The following is a description of a gene set: from publication Chen Y, Wang X (PMID 31504780) Human Gene Set: MIR15B_5P studied in species Homo sapiens Genes predicted to be targets of miRBase v22 microRNA hsa-miR-15b-5p in miRDB v6.0 with MirTarget v4 prediction scores > 80 (high confidence targets)., and this is the list of marker genes: RNF144B, LATS1, AHCYL2, CPEB2, APLN, NAA25 (NCBI Gene Id 80018), RBBP6, SIK1, SAMD10, SUMO3, ANKS1A, DENND4A, SEC24A, SYNRG, SUCO, KCNG4, RGMA, UBN2, BCL11B, DYNC1LI2, JARID2, RICTOR, ZNF449, SALL1, PRKAR2A, FAM135A, KRTAP11-1, TLK1, SGK1, PDIA6 (protein disulfide isomerase family A member 6), SIPA1L2, LAMP3, SLC2A3, DNAJA2, SEMA3D, CMC4, TMEM74B, SYDE2, MYO5B, RASSF8, SLC6A11, LURAP1L, C2orf42, QKI, PAFAH1B1, PCDH9, MIB1, CCDC83, MTFR1L, TARBP2, HECTD1, MCU, LUZP1, PAG1, CLUH, MAP2K1, JPH3, VTI1B, RFK, LDLRAD2, G2E3, SOX6, EZH1 (NCBI Gene Id 2145), SH3GL2, PLRG1, TMEM154, CHAC1 (NCBI Gene Id 79094), MAMSTR, CHUK, IARS1, HIGD1A (HIG1 hypoxia inducible domain family member 1A), ADRB2, RUNDC3B, ARMH4, ILDR2, TMEM199 (NCBI Gene Id 170473), SPTBN2, CCNJL, ZNF622, ATG9A, CXCR5, USP44, RASEF, RET, SPAG7, UROS, UBFD1, IKBKB, MEX3C, EXT2, ZCCHC2, MEOX2, NRP2, SEMA3A, ELL2, KCNJ2, PNPLA6, ZFHX4, IPPK, NSMF, ADAMTS3, SLIT2, FLT3, KRTAP4-6, COBLL1 (NCBI Gene Id 22837), PLXNC1, SEMA5B, PTPN4, GCC2, SLC4A4, ST8SIA3, RAD50, NUFIP2, TLL1, FBXL20, SYNJ1 (NCBI Gene Id 8867), ANLN, TFCP2L1, RBM6, GPN1, PTCH1, CMPK1, EPHB2, NOS1, G0S2, ATF6, CACUL1, MOB3B, PISD, CFAP45, AKT3, IPO7, KIF5C, PAPPA, BZW1, RARB, ANKUB1, PPP2R1B, TMEM135, PTPRR, NR2C2, SPRYD3, BMPR1A, SCN8A, FAM133B, SREK1, IVNS1ABP, ARPP19, TRANK1, CCNT1, SEPTIN2, HELZ, PPP1R11, DMPK, TMEM183A, TGFBR3, MOB4, NAPG (NSF attachment protein gamma), CASK, SOCS6, STOX2, ACSL4, CBX2, AGO1, ZNHIT6, PPT2, ARHGAP32, DIXDC1, NUP50, GALNT7, CDHR1, KIF1B, HERC6, CD2AP, HTR2A, ATXN1L, UBE4B, DPY19L4, SLC36A1, SNTB2, SAV1, AK4, CUX1, ASH1L, ZNRF2, USP3, SPRED1 (sprouty related EVH1 domain containing 1), FERMT2, PCMT1, PPM1A, NCS1 (neuronal calcium sensor 1), IL7R, AREL1, FGFR1, DLL1, HMGA1, WWC1, ATXN7L3, ZNF367, TBL1XR1, SEL1L3, ARHGAP20, AGO4, RIMKLB, STXBP3, ACVR2A, NECTIN1 (nectin cell adhesion molecule 1), USP25, SON, SEMA6D, YWHAH, XPO7, KDSR, SLC9A6, CDCA4, GPATCH8, ZC2HC1A, DNAJB4, POU2F1, VPS33B, TMC7, UNC5D, FGF9, LAMC1, EDA, USP15, AMER1, GRM7, SMAD7, NHLRC2, UBE2V1, TMEM268, CYB561A3, CHIC1, PRRC2C, MGAT4A, UBQLNL, ZC3H13, FAM81A, NRBP1, IFT74, COPS7B, SLC11A2, ZNF691, SMURF1, TRABD2B, MYB, CASR, PTH, ENSG00000275993, DDX3Y, DYRK1B, TMEM100, PCDH17, ABL2, NOB1, DENND2C, INSR, GNAT1, UTP25, PIP4P2, LITAF, ATXN7L1, GPR63, RTN4, KIF3B, RS1, ARL3, IGF1R, MYLK, IGF2R, DESI1, ZNRF3, MAP7, SALL4, TNFSF13B, DMTF1, HTR4, GATAD2A, AXIN2 (axin 2), ANKRD46, YRDC, FAM89A, ATG13, CSRNP1, TMEM245, WNT4, CCDC88C, STK33, CEP85L, RSBN1, SSR1, IHH, ZMAT3, CCNE1, STXBP5, ARIH1, CC2D1B, ZBTB44, ST7L, FOXK1, CDC37L1, DCLK1, SLC12A2, FBXO21, DENND1B, KCNN4, SYT4, PLXNA4, DDX3X, LSM11, MAN2A2, LRP6, C12orf76, SALL3, MAP3K13, ZNF275 (zinc finger protein 275), RORA, ISLR, TTC14, ELMOD1, CNOT6L, ARHGAP12, CDK8, WEE1, SNRPB2, PPP6R3, OTX1, WIPI2, EPB41L4B, SYT3, COP1, HSPA4L, CYP2S1, CLDN12, DEPDC4 (DEP domain containing 4), MKX, PPM1E, BCL2L2, ATG14, TFAP2A, RAD23B, RPS6KA3, ROCK2, CPEB3, RSPO3, AVL9, PLPP1, PTPN3, TMCC1, RECK, FBXW7, ABCF3 (NCBI Gene Id 55324), FASN, CDC42SE2, ELAC1, MYO5A, MBNL2, KCNK10, RETREG2, WNK3, CARM1, SIRT4, GFAP, PHF19, RAB11FIP2, NRN1, TRAM1, MOV10, BTRC, RASGEF1B, CACNA2D1, CDK17 (NCBI Gene Id 5128), CREBRF, ATXN2, PIAS2, SVIP, MIDEAS, FAM91A1, WNT3A, P3H2, ADAMTS6, CDC27, TRIM66, CD3E, ZCCHC3, TUBA4A, SCOC, MTMR3, SLC25A37, FGF7, SMURF2, USP31, SSTR3, ZDHHC15, MNT, BAG4, KIF5B, RUNX1T1, ZBTB46, KANK1, PAFAH1B2, ZBTB20, AMMECR1, GABARAPL1, EGLN1, C1QL3, LRRN3, UBE4A, CSDE1, NSG1, WNT7A, SRPRA, KPNA3, LYPLA2, SLC39A10, ETNK1, VEGFA, TSC22D2 (NCBI Gene Id 9819), UNC13A, ARFGAP2, TNRC6B, TAB3, CD47, TENM2, ZNF548, CCND1, RAB9A (NCBI Gene Id 9367), ANXA11 (annexin A11), UBE2Q1, OGT, MYBL1, PARVA, STRADB, ADGRL1, CD80, ARHGDIA, BTAF1, LRRK1, CHD2, RBPJ, ZBTB39, SLC20A2, PDE3B, TMEM178B, GAREM1, MASP1, ATXN7L2, PELI2 (pellino E3 ubiquitin protein ligase family member 2), LRIG1, MAP3K9, CAPZA2, ANO3, HMBOX1, MFN2, SESTD1, PTPRD, NAV1 (NCBI Gene Id 89796, neuron navigator 1), KIF23, KLHL2 (NCBI Gene Id 11275), HECTD4 (NCBI Gene Id 283450), CCND2, TGIF2, SNX16, CCDC6, N4BP1, GSTCD, SHOC2, DCP1A, RFX3, PEX13, GOLGA1, RNF217, EYA1, AMOT, RAB30, SLC13A3, LGR5, CDK5R1, OOEP, EPC1, HIPK2, MKNK1, LARGE2, ARL2 (ADP ribosylation factor like GTPase 2), GLS2, HEPHL1, PLAG1, SKI, CDC25A, AMOTL1, STXBP1, KCTD8, CBX4, CHPT1, SLC35G1, DRD1, MED26, CBX6, PRDM4, ARMCX2, CAPRIN1, ELL, BTG2, ENAH, KIF21A, NFATC3, RPS6KA6, ACVR2B, RREB1, CPSF7, TBP, GGA3, EPHA7, CLOCK, ZFHX3, RBM12, SOBP (NCBI Gene Id 654119), YTHDC1, USP42, PEDS1-UBE2V1, PIK3R1, RAB9B, ACOX1, PLEKHA1, TBPL1, ISM2, UBR3, CYP26B1, ZBTB34, LRIG2, GHR, RELN, FNTA, ZSCAN31, UNC80, E2F3, SYPL1, CACNA1E, RBM24, COL12A1, MYRIP, OMG, SEH1L, SUZ12, GALNT13, NF1, EXOC3L2, SERBP1, PIP4P1, HOXA10, LRP2, SLC2A14, DLEU7, TCAIM, SETD3, ZMYM2, SPTLC1, CLCN4, MYEF2, CEP55, SESN1, ABHD2, RIF1, SMIM13, RNF10, PDK4, PABIR2, PDZD8, FGF2, HSPG2, C1orf21, VPS4A, WBP11, CHEK1 (checkpoint kinase 1), CPD, FAM110C, ACTR2, ATXN7L3B